Given this list of marker genes IQCA1 (NCBI Gene Id 79781), DTYMK, MYO5A, HAMP, HES1, USP40, ASB1, SCLY, RPS6, GAL3ST2, CXCL11, RNPEPL1, NEU4, UGT1A10, SEPTIN4, PDGFA, IL13RA1, ASB18, UGT1A1, MAP1LC3B, CYTH4, UGT1A6, RBM44, KIF1A, OR6B3, NFKBIA, LRRFIP1, IL1B, ARF1, TRPM8, AGXT, DISC1, HJURP, ANO7, GPR35, OTOS, MAP4, STK25, ING5, FARP2, PPP1R7, MIR149, RTP5 (receptor transporter protein 5 (putative)), EEF1A1, ITGB3, OR6B2, MYOD1, MSL3B, GABARAPL1, SEPTIN6, D2HGDH, EGFR, MTERF4, DUSP28, CXCL12, SNED1, GYS1, PRL, MIR3133, RAB27A, MIR4441, PDCD1, HDLBP, HDAC4, RRAGA (Ras related GTP binding A), GPC1 (NCBI Gene Id 2817), ABCA1, AGAP1, UGT1A4, JUN, PRLH, RAMP1, COPS8, AQP12A, CXCR4, MIR4440, TWIST2, UGT1A7, CALCA, MEF2A, IRF8, TP53 (tumor protein p53), AGAP1-IT1, MAB21L4, GBX2, RAB17, MLPH, PDX1, NEDD8, HES6, BOK, TRAF3IP1, SEPTIN12, DGKD, KLHL30, NDUFA10, RRAGC, PER2 (period circadian regulator 2), MROH2A, RAC1, PASK, MIR4786, CYTH3, GABARAP, ASCL1, DNAJB3, CYTH2, COPS9, ILK, TRAF3, MYOG, CAPN10, MEF2C, SEPTIN2, TNF, MIR2467, GABARAPL2, UBE2F, MIR4269, RRAGD, MAP1LC3A, ACKR3, ERFE, CYTH1, ANKMY1, CENPA, ITPK1, SPP2, UGT1A8, COL6A3, UGT1A9, ILKAP, MAP1LC3C, CALCRL, THAP4, AQP12B, ARF5, CALM1, SH3BP4, ATG4B, ARL4C, CFLAR, GMEB1, ESPNL, RRAGB, here is a description of the gene set: Human Gene Set: WP_2Q37_COPY_NUMBER_VARIATION_SYNDROME species: Homo sapiens 2q37 copy number variation syndrome